The following is a description of a gene set: Chromosome breakage Human Gene Set: HP_CHROMOSOME_BREAKAGE Elevated rate of chromosomal breakage or interchanges occurring either spontaneously or following exposure to various DNA-damaging agents. This feature may be assayed by treatment of cultured lymphocytes with agents such as chemical mutagens, irradiation, and alkylating agents. studied in species Homo sapiens, and this is the list of marker genes: BRIP1, XRCC2, RAD51, MCM4, TERT, RAD50, SUFU, SLX4, COX4I1, DNAJC21, MAD2L2, UBE2T, BRCA2, PIK3CA, FANCE, AKT1, DCLRE1B, BLM, TRAF7, BRCA1, SMARCE1, NF2, FANCL, TMEM185A, SMO, FANCI, RNF168, FANCC, BAP1 (NCBI Gene Id 8314), FMR1, FANCF, FANCD2, RAD51C, ERCC4 (NCBI Gene Id 7509), PALB2, SMARCB1, PDGFB, FANCA